The following is a description of a gene set: part of: Nuclear Envelope Breakdown This event has been computationally inferred from an event that has been demonstrated in another species.<p>The inference is based on the homology mapping from PANTHER. Briefly, reactions for which all involved PhysicalEntities (in input, output and catalyst) have a mapped orthologue/paralogue (for complexes at least 75% of components must have a mapping) are inferred to the other species. electronically inferred by orthology from the curated human pathway Reactome Pathway: Depolymerization of the Nuclear Lamina species: Mus musculus, and this is the list of marker genes: Lmnb1, Lmna, Prkca, Emd, Cdk1, Ctdnep1, Ccnb1